The following is a description of a gene set: Any process that modulates the frequency, rate or extent of JUN kinase activity. studied in species Homo sapiens Human Gene Set: GOBP_REGULATION_OF_JUN_KINASE_ACTIVITY, and this is the list of marker genes: SERPINB3, MAP3K7, TRAF2, MAP4K2, MAP3K5 (mitogen-activated protein kinase kinase kinase 5), MAP3K4, TAOK3, MAPK8IP1, PTPN1, PDCD4, MAP3K10, ERN1, DNAJA1, TRAF6, NPPA, PTPN22, AIDA, SASH1, TNF, TLR6, ARHGEF5, HIPK3, MAP3K11